Given this list of marker genes Gstm7, Casq2, Ehmt2, Th, Oprm1, Rad51, Htr1b, Cacna1s, Casp6, Adcy8, Ryr2, Ccna2, Star, Slc1a1, Ryr1, Tmem38b, Ppp1r9b, Trpv1, Slc8a1, Tgm2, Crh (NCBI Gene Id 383938), Chek1, Blm, Casp7, Spidr, Mecp2, Recql5, Mdm2, Ryr3 (ryanodine receptor 3), Ppp1r1b, Slc1a2, Abcb1a, Selenon, Tmem38a, Fancb, Comt, Slc1a3, Bcl2l1, Crhbp, Casp3, here is a description of the gene set: studied in species Mus musculus Any process that results in a change in state or activity of a cell (in terms of movement, secretion, enzyme production, gene expression, etc.) as a result of an alkaloid stimulus. Alkaloids are a large group of nitrogenous substances found in naturally in plants, many of which have extracts that are pharmacologically active. Mouse Gene Set: GOBP_CELLULAR_RESPONSE_TO_ALKALOID